The following is a description of a gene set: A synapse that uses acetylcholine as a neurotransmitter. Mouse Gene Set: GOCC_CHOLINERGIC_SYNAPSE species: Mus musculus, and this is the list of marker genes: Pld1, Kcnb1, Chrna10, Chrnb4, Chrnb2, Slc18a3, Chrna9, Rph3a, Dlgap3, Slc10a4, Nefl, Gpr151, Slc22a2, Chrm2, Chrna3, Ano6, Brsk1, Dlgap4, Chrna7, Chrna5, Chrna4, Chrm1